Given this list of marker genes ZNF395, ZYG11B, COL4A2, PROX1 (NCBI Gene Id 5629), RCAN1, MGAT5B, PKP4, TSEN15, MTMR12, GTF2F1, ACBD3, DPYD, MTMR9 (myotubularin related protein 9), CHRAC1, PDGFRB, SYT4, ST8SIA3, PPP4R2, TMCC3, RALGPS2, ADK, NUP210, S100PBP, INCENP, MAP2K1, IPO9, E2F5, RHOQ, RECK, DCTN5 (dynactin subunit 5), ARHGAP36, FAH, CPSF6, SFT2D1, ZNF207, MLLT3, SMARCC1, HACE1, PPP1R16B, B3GALNT1, STC1, MTAP, SLC38A1, SYT1, PDGFRA, ARGLU1, KCNK3, HMGN4 (NCBI Gene Id 10473), CYREN, CALB1, MAPK1IP1L, SNX15, SAR1A, FUT8, MBLAC2, LRRC40, DDX17, SNAI1, NOL10, TMEM184B, PAQR3, FIGN, CREB5, DNAJC24, PLPBP, ALDH5A1, FAM120AOS, TPD52, ZFPL1, GALNT7, MRPL10, MYB, SNX12, GLCE, JAKMIP1, TTC33, ATPAF1, FAM76A, PAM, SLC7A2, CYB5B (cytochrome b5 type B), ERLIN1, LGR4, ACSL4, HMGCS1, NUMBL (NUMB like endocytic adaptor protein), TMEM35A, BCL11B, MID1, ANXA5, METAP1, GORASP2, ZCCHC24, CD47, RXYLT1, SLC44A1, CRTAP, CASP2, MDM4, GINS3, GMFB, KANK2, RAB43, PMF1, TFDP2, HIP1, PER2, EPB41, PKIA, PNPLA8 (patatin like phospholipase domain containing 8), SMAD4, PALLD, MPP2, OBSL1, NAGPA (NCBI Gene Id 51172), PLAGL1, JPH1, RAB29, GOLPH3L, NPHP3, BAZ2A, CTSB, AK2, PIP5K1A, GPALPP1, SWAP70, ASXL2, MSANTD3 (Myb/SANT DNA binding domain containing 3), FAM167A, KIT (KIT proto-oncogene, receptor tyrosine kinase), METTL16, EARS2, ARHGAP1, TENT5A, NAA50, SGPP1, PIP4P2, RPL28 (ribosomal protein L28), SOX9, ARPP19, CDK6, AAGAB, FLOT2, FKBP1B, CTNND2, RBBP5, here is a description of the gene set: studied in species Homo sapiens Human Gene Set: WEI_MIR34A_TARGETS Loss of 1p36 heterozygosity commonly occurs with MYCN amplification in neuroblastoma tumors, and both are associated with an aggressive phenotype. Database searches identified five microRNAs that map to the commonly deleted region of 1p36 and we hypothesized that the loss of one or more of these microRNAs contributes to the malignant phenotype of MYCN-amplified tumors. By bioinformatic analysis, we identified that three out of the five microRNAs target MYCN and of these miR-34a caused the most significant suppression of cell growth through increased apoptosis and decreased DNA synthesis in neuroblastoma cell lines with MYCN amplification. Quantitative RT-PCR showed that neuroblastoma tumors with 1p36 loss expressed lower level of miR-34a than those with normal copies of 1p36. Furthermore, we demonstrated that MYCN is a direct target of miR-34a. Finally, using a series of mRNA expression profiling experiments, we identified other potential direct targets of miR-34a, and pathway analysis demonstrated that miR-34a suppresses cell-cycle genes and induces several neural-related genes. This study demonstrates one important regulatory role of miR-34a in cell growth and MYCN suppression in neuroblastoma. Potential direct target genes for MIR34A microRNA in IMR32 cells (neuroblastoma). from publication Wei JS, Song YK, Durinck S, Chen QR, Cheuk AT, Tsang P, Zhang Q, Thiele CJ, Slack A, Shohet J, Khan J (PMID 18504438)